The following is a description of a gene set: The chemical reactions and pathways resulting in the breakdown of the peptide bradykinin. species: Homo sapiens Human Gene Set: GOBP_BRADYKININ_CATABOLIC_PROCESS, and this is the list of marker genes: ECE1, CPN1, CTSH (cathepsin H), XPNPEP1, MME, ACE, IDE